Given this list of marker genes Nupr1, Tnfrsf19, Igbp1, Adra2c, Car3, Cryl1, Cdh16, Zfp36l2, Lipe, Epcam, Igkv4-59, Map3k1, Efhd1, Cldn5, Igkv4-74, Id2, Cxcr4, Prss23, Use1, Cdkn1c, Btg1, Arhgef3, H2-Q5, Sdc4, Sp4, Supt4a, Ltf, Gjb2, Efna1, Scx, Cd55, Krt18, Akr1c13, Ighv5-12 (NCBI Gene Id 668395, immunoglobulin heavy variable 5-12), Pkp2, Ppp2r5a, Itgb4, Crip2, AU021092, Lpl, Blnk, Efnb2, Pam, F3, Fam107b, Ighg2b, Igkv4-73, Adipoq, C3, Tacstd2, Ifit3, Ifi27l2a, Hmga2, Ddit4 (NCBI Gene Id 74747), Ifih1, Tmem106c, Tmem30b (NCBI Gene Id 238257), Abcb1a, Ptprr, Tgif1, Dram2, Capg (NCBI Gene Id 12332), Nop53, Prxl2a, Tprg1l, Ccn2, Prnp, 2310010J17Rik, Igkv4-68, Cfd, Med24, Htra3, Wls, Ces2g, Igkv4-79, Retn, Dsp, Slc27a1, Ifit2, Me1, Perp, Tec (NCBI Gene Id 21682), Saa3, Ghr, Arl4c, Scd1, here is a description of the gene set: Genes co-regulated in uterus during a time course response to progesterone: SOM cluster 6. Human infertility and recurrent pregnancy loss caused by implantation defects are poorly understood. Hoxa-10-deficient female mice have severe infertility and recurrent pregnancy loss due to defective uterine implantation. Gene expression profiling experiments reveal that Hoxa-10 is an important regulator of two critical events in implantation: stromal cell proliferation and local immunosuppression. At the time of implantation, Hoxa-10 mediates the progesterone-stimulated proliferation of uterine stromal cells. Hoxa-10 mutants express a stromal cell proliferation defect that is accompanied by quantitative or spatial alterations in the expression of two cyclin-dependent kinase inhibitor genes, p57 and p15. Hoxa-10 deficiency also leads to a severe local immunological disturbance, characterized by a polyclonal proliferation of T cells, that occurs in place of the normal progesterone-mediated immunosuppression in the periimplantation uterus. Mouse Gene Set: YAO_TEMPORAL_RESPONSE_TO_PROGESTERONE_CLUSTER_6 from publication Yao MW, Lim H, Schust DJ, Choe SE, Farago A, Ding Y, Michaud S, Church GM, Maas RL (PMID 12554760) species: Mus musculus